Given this list of marker genes HERC5, CXCL10, IFIT1, RSAD2, ISG15, CCL2, USP18 (NCBI Gene Id 11274), NFKB1, LAMP3, NFKB2, here is a description of the gene set: Genes up-regulated in peripheral blood mononuclear cell 1d vs 0d in adults (18-55) after exposure to rVSV-ZEBOV, time point 1D Human Gene Set: RECHTIEN_PBMC_RVSV_ZEBOV_AGE_18_55YO_1DY_UP from publication Rechtien A, Richert L, Lorenzo H, Martrus G, Hejblum B, Dahlke C, Kasonta R, Zinser M, Stubbe H, Matschl U, Lohse A, Krähling V, Eickmann M, Becker S, VEBCON Consortium, Thiébaut R, Altfeld M, Addo MM (PMID 28854372) studied in species Homo sapiens Predicting vaccine efficacy remains a challenge. We used a systems vaccinology approach to identify early innate immune correlates of antibody induction in humans receiving the Ebola vaccine rVSV-ZEBOV. Blood samples from days 0, 1, 3, 7, and 14 were analyzed for changes in cytokine levels, innate immune cell subsets, and gene expression. Integrative statistical analyses with cross-validation identified a signature of 5 early innate markers correlating with antibody titers on day 28 and beyond. Among those, IP-10 on day 3 and MFI of CXCR6 on NK cells on day 1 were independent correlates. Consistently, we found an early gene expression signature linked to IP-10. This comprehensive characterization of early innate immune responses to the rVSV-ZEBOV vaccine in humans revealed immune signatures linked to IP-10. These results suggest correlates of vaccine-induced antibody induction and provide a rationale to explore strategies for augmenting the effectiveness of vaccines through manipulation of IP-10.